The following is a description of a gene set: A spindle that forms as part of mitosis. Mitotic and meiotic spindles contain distinctive complements of proteins associated with microtubules. studied in species Homo sapiens Human Gene Set: GOCC_MITOTIC_SPINDLE, and this is the list of marker genes: LIMK2, CUL3, TADA2A (NCBI Gene Id 96291), YPEL5, TRAT1, NUDCD2, NIN, CDC14C, SPAG5, PYCR3, RTRAF, TUBB6, KIF23, PKP4, SLC34A1, DIAPH1, KIF11, DNAAF5, KAT5, CDC14A, TPX2, CKAP2L, ECT2, MAPRE1, CCDC117, STAG2, TUBB (tubulin beta class I), STAG1, KAT14, TUBB8, KIF18B, AURKB, KMT5B, RMDN1, AAAS, EML3, TACC3, OR2A4, HAUS4, CLASP2, TAF1D, HNF4G, CKAP5, HAUS6, CDC16, TADA3, CAPG, MAP10, ESPL1, SKA1 (NCBI Gene Id 220134), WAPL, SGF29, MAD1L1, WNK1, GPSM2 (G protein signaling modulator 2), IFT43, RACGAP1, SIRT2, FLCN, TUBB2B, KIF2A, PHLPP2, CD180, EFHC1, TUBB1, HAUS8, MAPRE3, KIFC1, MBIP (NCBI Gene Id 51562), GOLGA2, MISP, DNALI1, EML4, CDC14B, NEDD9, KIF20A, SMC3, DZIP1L (DAZ interacting zinc finger protein 1 like), TFDP2 (NCBI Gene Id 7029), LSM14A, KIF22, IKBKG, TPPP, NUMA1, DPYSL2, CTTN, GEM, SPESP1, ATAT1, KIF18A, KAT2B, RCC2, CKAP2, KNSTRN, KATNBL1, IK, CXCR2, TUBB4B, DYNLL1, TBL1X, GIT1, DLGAP5, MAK (NCBI Gene Id 4117), TRAPPC14, AGBL5, TUBG1, FAM83D, CDK1, ARHGAP6, MYF6, BCCIP, SPOUT1 (NCBI Gene Id 51490), ASPM, PKD2, CCSAP, FAM161A, SMC1A, HAUS2, CDC7, KAT2A, YEATS2, WDR5, CDK5RAP2, TUBB4A, PTPN7, TUBB2A, DCTN1, PRC1, TBL1XR1, POLDIP2, HSF1, GPX2, TNKS, AURKA, CLASP1, TMEM9, MAP4, NCOR1, CEP295, HNRNPU, DCDC1, ADRB2, RAE1, NUP62, PKHD1, SKA3, PLK1, MAP1S, HDAC3, NUSAP1 (NCBI Gene Id 82534), MAP9, NUDC, USP44 (NCBI Gene Id 84101), CLTC, TBCK, HAUS5, KLHL22 (NCBI Gene Id 84861), DR1, RANGAP1, ZZZ3, ARHGEF7, NSMCE1, CDC42, HAUS1, RMDN3, MAD2L1, DYNLT3, HECW2, TUBB3, IFT88, TUBB8B, ANAPC7, KIF20B, NGRN, RPS3, MAPK1, CNTRL, HAUS7, CENPE, ODAM, HAUS3, NEIL2, CDC6, EML2, EPB41, MAPKBP1, KATNAL1, KATNA1, SMC6, HEPACAM2, TPR, EML1 (EMAP like 1), RMDN2, CDC27